The following is a description of a gene set: Inappropriate excess of the steroid hormone aldosterone, which is a mineralocorticoid receptor (MR) agonist, is associated with increased inflammation and risk of cardiovascular disease. MR antagonists are cardioprotective and antiinflammatory in vivo, and evidence suggests that they mediate these effects in part by aldosterone- independent mechanisms. We used affymetrix to characterize the effect of Mineralocorticoid Receptor deletion on macrophage transcriptional profile, and identify its requirement in normal glucocorticoid signalling. species: Homo sapiens Human Gene Set: GSE23308_CTRL_VS_CORTICOSTERONE_TREATED_MACROPHAGE_MINERALCORTICOID_REC_KO_UP Genes up-regulated in macrophages with NR3C2 knockout: untreated versus corticosterone. from publication Usher MG, Duan SZ, Ivaschenko CY, Frieler RA, Berger S, Schütz G, Lumeng CN, Mortensen RM (PMID 20697155), and this is the list of marker genes: TBC1D22A, FRMD6, PROKR1, TOPORS, GLB1, SNRPB2, CLSTN1, CKB, FBXW7, CTDP1, LIPA, DCTN1, PTDSS2, MSRA, PIP4K2C, STX8, CNR2, TEX261, PLPP2, JADE1, DTD1, RELL1, TAF8, SNAPIN, CHEK2 (checkpoint kinase 2), COMT, YPEL5, OSGEP, ARRB1, POT1, CD300C, INTS6L, SLC35C2, MTHFD1, CRIP3, CTDSP2, STK10, SMARCC1, PHF13, FIG4, DHRS7, SPPL3, RBKS, THUMPD3, CBX2, SCAMP2, VRK2, KDM2B, NAGK, MRPS24, BSCL2, CERK, TFEB, ANAPC15, SRP14, FOXJ2, DHX57, DEF8 (NCBI Gene Id 54849), ZFP30, C6orf62, DMAC2, ME2, IL6R, MAP2K3, MCM4, MIS18A, POLL, ELP3, GLO1, TMEM150B, IL7R, SMPDL3A, ENTREP3, RGS14, DHRS4, GNAS (GNAS complex locus), FBXO11, TRIM25, OCEL1, STK38, RAB29, ADAMTS10, TCN2, IVNS1ABP, EZH1, MCM2, SRD5A3, DNPEP (aspartyl aminopeptidase), TJP3, DCAF8, WDSUB1 (WD repeat, sterile alpha motif and U-box domain containing 1), WDFY1, BET1 (Bet1 golgi vesicular membrane trafficking protein), SFXN3, DOP1B, CIC, NRDE2, SLC66A1, BTBD2, UAP1L1, UCHL5 (ubiquitin C-terminal hydrolase L5), LYL1 (LYL1 basic helix-loop-helix family member), TM7SF3, POR, ETAA1, DIPK2A, TP53INP1, ARHGAP17, TCF3, RNF187, NPRL2, TMEM129, ETFDH, SNRPD2, PURG, TTC5, TUBB2A, MESD, AP3M2 (adaptor related protein complex 3 subunit mu 2), RPA1, NUP85, FEN1, PANK1, PURA, MBNL1, PJA1, HAUS3, GPSM3 (G protein signaling modulator 3), MTX1, ANKRD28, ZNF362, DCAF15, GALNS, TOM1, AKAP8L, YIPF3, ALDH4A1, NEU1, HMG20B, PRKACB, CDADC1, RHOBTB2 (NCBI Gene Id 23221), ORC5, S1PR1, TNS1, ASRGL1, PTPA, CD99L2, GJA4, HTATIP2, CAMK2G, CTNNBIP1, PSME3IP1, RTN4, TRPV2, SPICE1, ACADM, SMAD4, SLC25A39, PHKG2, P2RX7, ST3GAL2 (NCBI Gene Id 729518), SEC14L1, MORN4, CLEC7A, TF, ABHD8, TCTN3, MXI1, TPGS1, TAOK3, PRKCI, ULK2, LRRC40, CEP19, NCAPH2, LPCAT1, FANCE, RMND5B, RNF167, JMJD1C, INPP4A, AFG1L, FOXO3, ADCK1, NHERF1 (NCBI Gene Id 9368), COX6A1, NOXO1 (NADPH oxidase organizer 1), SNRK, ZNF219, TMED4, ABHD4, TTC3, TP53INP2, PRPF6, MYO9B, B3GALNT1, RBM43, ZDHHC4, RREB1